The following is a description of a gene set: The chemical reactions and pathways involving any amino sugar, sugars containing an amino group in place of a hydroxyl group. Human Gene Set: GOBP_AMINO_SUGAR_METABOLIC_PROCESS species: Homo sapiens, and this is the list of marker genes: GFPT2, MGAT3, RENBP (renin binding protein), CTBS, LARGE1, GFPT1, CHST7, SLC35A3, HEXB, CHST4, GNPDA2, AMDHD2, OGA, UAP1, PGM3, CHI3L1, CHIA, FN3K, CHIT1, GNPNAT1 (NCBI Gene Id 64841), NPL, CHI3L2, SLC35A1, ST3GAL1, GNPDA1, CHST3, ALDH1A1, GNE, CHST1, B4GALNT2, NAGK, CHST5, ST6GAL1, NANP, OVGP1, NANS, CHST6, MGAT1, EXTL2, CSGALNACT1, UAP1L1, CHST2, CMAS